The following is a description of a gene set: Human Gene Set: GOCC_HOST_CELLULAR_COMPONENT Any cellular component of a host cell. The host is an organism in which another organism, for instance a parasite or symbiont, spends part or all of its life cycle and from which it obtains nourishment and/or protection. species: Homo sapiens, and this is the list of marker genes: DYNLT1, CLEC4M, NUP153, KPNA2, IFIT1, CD209, KPNA3, KPNA6, NMT2